Given this list of marker genes Palb2, Tll1, Nr2f1, Robo1, Heyl, Ccdc40, Sim2, Tbx1, Hhex, Plxna2, Folr1, Emx1, Neurog1, Hoxa2, Hipk2, Tbc1d32, Wnt5a, Hoxd12 (NCBI Gene Id 15432), Erbb4, Ptch1, Shh, Sostdc1, Pcgf2, Crb2, Sfrp1, Invs, Lhx3, Kdm2b, Hoxb9, Mtf2, Hoxb5, Gdf3, Pax7, Spry1, Smad6, Dll4, Apc, Lhx2, Adgrg1, Nr2f2, Hey1, Uncx, Rfx3, Pld6, Mnx1, Gdf11, Asph, Arc (activity regulated cytoskeletal-associated protein), Fkbp8, Arl13b, Acd, Fgf3, Gm572, Mapk8 (mitogen-activated protein kinase 8), Tgfbr1, Galnt11, Aurka, Fgf10, Bhlhe41, Syngap1, Bmp5, Bmp1, Meis3, Dnaaf4, Daam2, Ldb1, Six3, Zeb2 (NCBI Gene Id 319891), Pcdh8, Dll1, Prkdc, T, Fgfr4, Pgap1, Ihh, Eed, Sema3a, Pax3, Fst, Rax, Axin2, Hes6, Foxg1, Dnah11, Ddit3, Pcsk5, Ift52, Lbx1, Ednra, Hoxa1, Tdrd7, Meox2, Gata5, Irx4, Aplnr, Kif3a, Cimap3, Gpr161, Wnt1, Lfng, Ripply2, Lhx1, Enkur, Mosmo, Scmh1, Kat2a, Ror2, Trp63, Hoxb8, Prop1, Dkk1 (dickkopf WNT signaling pathway inhibitor 1), Sp8, Ap1b1, Ctnnbip1, Lrp2, Ooep, Nodal, Aldh1a2, Foxn4, Pax6 (paired box 6), Irx3, Ets2, Yy1, Irx1, Trp53 (NCBI Gene Id 22059), Notch2, Gsx2, Ntf5, Dnai2, Hoxd11, C2cd3, Cyp26c1, Hoxc6, Ppp2r3a, Ripply1, Rbpj, Dmrt3, Fgf1, Prickle1, Gas1, Dnaaf1, Cdon, Tbx20 (T-box 20), Pkd1l1, Senp2, Ift172, Nckap1, Tcf15, Wnt2b, Hes3, Tbx6, Pierce2, Cirop, Tulp3, Nkx3-1, Kdm6a, Ascl1, Fgfr2, Sufu, Mdfi, Hes1, C3, Pax8, Hand2, Ttn (titin, NCBI Gene Id 99250), Mical2, Ccdc39, Ift140, Gli2, Wnt2 (wingless-type MMTV integration site family, member 2), Tbx2, Mns1, Wnt7a, Mks1, Bmp7, Ift88, Evx1, Apc2, Rfng, Notch1, Tdrd5, Mef2c, Rarg, Otx2, Hoxc4, Xrcc2, Lmx1b, Disp1, Mfng, Hoxa5, Smad3, Map3k4, Acvr1, Celsr2, Egr2 (early growth response 2), Abi1 (NCBI Gene Id 214715), Mllt3, Six1, Tbr1, Acvrl1 (NCBI Gene Id 11482), Wls, Nrp2, Wnt11, Dlx2, Pcsk6, Tra2b, Hoxb1, Smad5, Foxd1, Wdr19, Rpgrip1l, Pskh1, Med12, Cripto, Bicc1, Nat8f5, Fbxl15, Nle1, Meox1, Mesp1, Bmpr2, Cited2, Dbx1, Dmrt2, Tifab, Cer1, Dzip1l, Osr2 (odd-skipped related 2), Hoxc11, Ift74, Daw1, Chsy1, Hoxd10, Foxa1, Poglut1, Ift122 (NCBI Gene Id 97320), Cdx2, Myf5, Cc2d2a, Rnf111, Mib1, Rnf220, Zic1, Drc1, Tcf7l1, Ring1, Tcap, Zic3, Tmed2, Foxc1, Dnaaf11, Grem2 (NCBI Gene Id 23893), Osr1, Wdr77, Gorab (NCBI Gene Id 98376), Dvl1, Zic2, Bcor, Gbx2, Rfx4, Bmp4, Lama5, Sfrp2, Dlx1, Nkx3-2, Hand1, Mdga2, Mmp21, C1qa, Dnah5, Ifitm1, Eomes, Ar, Cfap52, Kmt2a, Hoxd3, Pierce1, Lefty2, Wnt3, Frs2, Hoxd13, Hoxc5, Fezf1, Dll3, Nbl1, Foxj1, Cplane2, Psen2, Robo2, Hoxb7, Smad2, Taf10, Peg12, Eng, Satb2, Frat1, Sox17, Prkacb, Hnf1b, Tmem107, Alx4, Rnf2, Ift25, Ift57, Traf3ip1, Prkaca, Gas8 (NCBI Gene Id 83455), Chrd, Dnaaf3, Gli1, En1, Nek8, Ctnnb1 (catenin beta 1), Tdrd6, Myf6, Acvr2b, Hoxa9, Cdx4, Foxa2, Tctn1, Aida, Nkx2-1, Lef1, Cep290, Emx2, Hoxd4, Snai1, Tgfbr2, Nrarp, Wnt7b, Grhl3, Tll2, Megf8, Atm, Psen1, Tbx18, Neurod1, Tbx3, Atp6ap2, Htt, Fezf2, Dnaaf2, Fuz, Cyp26b1, Cdk20, Pofut1, Odad3, Smad1, Cited1, Nanog, Btg2, Pds5a, Hoxa3, Hhip, Nkx2-5, Wnt3a, Irx2, Rab23, Pbx1, Anks6, Msgn1, Hoxa4 (homeobox A4), Nrg3, Sf3b1, Cfap45, Pitx2, Bmpr1a, Dvl2, Cdx1, Ofd1, Ext1, Dmrta2 (NCBI Gene Id 242620), Hipk1 (homeodomain interacting protein kinase 1), Pkd2, Hoxb3, Zeb1, Srf, Hif1a, Grsf1, Alx3, Fzd5, Sema3f, Edn1 (endothelin 1), Nog, Tmem67, Bmi1, Ccdc103, Pax2, Msx2, Hoxb2, Wnt8a, Vangl2, Hoxa7 (homeobox A7), Odad4, Tdrkh, Helt, Rttn, Hes2, Noto, Fgf8, Ski, Epb41l5, Dand5, Efnb1, Cyp26a1, Lrp5 (NCBI Gene Id 16973), Pbx2, Nme7, Foxc2, Ep300, Hoxc13, Hey2, Tgif1, Nkx2-2, Gja1, Itgam, Alx1, Asb2, Wt1, Isl1, Vax2, Ttc21b, Eya1, Tdrd1, Hes5, Acvr1c, Odad2, Sox1, Hoxb6, Ripply3, Cluap1 (clusterin associated protein 1), Fgfr1, Tfap2a, Zbtb16, Meis1, Hoxa11, Hoxc8, Lrp4, Gata4, Meis2 (Meis homeobox 2), Smad4, Hoxc9, Kdm2a, Bptf, Cobl, Hoxd8, Bmp2, Dpcd, Hoxc10, Msx1, Gdnf, Grem1, Tasor, Axin1, Chrdl1, Cfc1, Stil, Gsc, Reln, Hoxa6, Otx1, Intu, Lrp6, Sema3c, Dop1b, Bhlhe40, Nrp1, Dync2h1, Dchs1, Gli3, Ttc8, Barx1, Alg5, Foxb1, Bmpr1b, Hoxa10, Smarcd3, Nphp3, Tbx5, Wnt6, Tshz1, Ssbp3, Celsr1, Acvr2a, Mafb (NCBI Gene Id 16658), Setdb2, Cramp1, Cfap53, Shroom3, Ovol2, Crkl, Gpc3, Mesp2, Foxh1, Dync2li1, Rnf207, Foxf1, Smo, Fgf2, Hoxd9, Dnai1, Pax1, Hes7, Bhlhe22, Stc1 (NCBI Gene Id 20855), Six2, Lefty1, Hoxb4, here is a description of the gene set: Mouse Gene Set: GOBP_PATTERN_SPECIFICATION_PROCESS species: Mus musculus Any developmental process that results in the creation of defined areas or spaces within an organism to which cells respond and eventually are instructed to differentiate.